Given this list of marker genes PRKCQ, CD27, BCL3, DOCK8, PTCRA, IL7R, RAG1, JAK3, ARG2, TSC22D3, SLC46A2, BCL2, RORC, EFNA1, HIF1A, CCL5, GPAM, FADD, ST3GAL1, ADA, IDO1, BMP4, KIFAP3, BCL11B, PIP, here is a description of the gene set: studied in species Homo sapiens Human Gene Set: GOBP_NEGATIVE_REGULATION_OF_T_CELL_APOPTOTIC_PROCESS Any process that stops, prevents, or reduces the frequency, rate or extent of T cell death by apoptotic process.